The following is a description of a gene set: Mouse Gene Set: GOBP_INTRA_GOLGI_VESICLE_MEDIATED_TRANSPORT The directed movement of substances within the Golgi, mediated by small transport vesicles. These either fuse with the cis-Golgi or with each other to form the membrane stacks known as the cis-Golgi reticulum (network). studied in species Mus musculus, and this is the list of marker genes: Cog5, Copb2 (NCBI Gene Id 50797), Vti1b, Gosr2, Copz2, Cog2, Rab33b, Copg1, Trappc3, Nsf, Gosr1, Rab6b, Cux1, Cope, Cog4, Cog6, Copb1, Trappc10, Copg2, Copz1, Golga5, Copa, Cog1, Rab6a, Vti1a, Cog3 (component of oligomeric golgi complex 3), Trappc3l, Cog7, Gabarapl2, Cog8